Given this list of marker genes ATP6V1E1, ATP6V1D, ATP6V1G1 (ATPase H+ transporting V1 subunit G1), FLVCR1, ATP6V1G3, IREB2, SLC11A2, GLRX3, FTMT, SLC46A1, ATP6V0A2, SKP1, UBC, ATP6V1H, ATP6V0E2, ATP6V1B2 (NCBI Gene Id 526), ATP6V1G2, FBXL5, UBB, ATP6V1B1, ATP6V1F, TCIRG1, CAND1, ATP6V0D2, ALAD, ATP6V0C, TFR2, FTH1, SLC22A17, ATP6V1A, CYBRD1, CP, ATP6AP1 (NCBI Gene Id 537), CUL1, ATP6V0E1, ACO1, HMOX2, ATP6V0A4, HEPH, STEAP4, ABCG2, HFE, ATP6V0D1, ATP6V1E2, TF, RPS27A, NEDD8, UBA52, ATP6V0A1, ATP6V1C1, LCN2, ATP6V1C2, STEAP3, SLC40A1, ATP6V0B, HMOX1, FTL, TFRC, MCOLN1, here is a description of the gene set: The transport of iron between cells is mediated by transferrin. However, iron can also enter and leave cells not only by itself, but also in the form of heme and siderophores. When entering the cell via the main path (by transferrin endocytosis), its goal is not the (still elusive) chelated iron pool in the cytosol nor the lysosomes but the mitochondria, where heme is synthesized and iron-sulfur clusters are assembled (Kurz et al,2008, Hower et al 2009, Richardson et al 2010). part of: Transport of small molecules Reactome Pathway: Iron uptake and transport species: Homo sapiens